The following is a description of a gene set: Mouse Gene Set: ANP32E_TARGET_GENES from publication Yevshin I, Sharipov R, Kolmykov S, Kondrakhin Y, Kolpakov F (PMID 30445619) studied in species Mus musculus Genes containing one or more binding sites for (Anp32e) in their promoter regions (TSS -1000,+100 bp) as identified by GTRD version 20.06 ChIP-seq harmonization., and this is the list of marker genes: Rdh5, Rbms1, Eef1a1, Mir1955 (microRNA 1955), Fnbp4, Casp8ap2, Gm15991, Bloc1s1, Zfr, Fbxo46, Gcc1, Lrif1, Hexim2, Dctn4, Ten1, Kctd12, Spata2, Gm22711, Cradd, Slc38a2, Polr2m, Rnase4, Abcb10, Pim1, Osbp, Wbp1l, Parp11, Gm37885, Spaar, Snapc3, Incenp, Tmem150a, Snrpg, 2610005L07Rik, Ddah2, AA914427, Ubl3, Mtbp, Dnttip1, Prim1, Mettl2, Hivep1, Ciao1, Hadhb, Fry, Rab14, Mrpl24, Atpsckmt, A230083N12Rik, Eml4, Mir207, Flna, Zranb2, Atox1, Sgk1, Sh3yl1, Hmg20b, Ubap1, Wdr83, Cnot3, Yap1, Nt5c3, Tpp2, Fam222a, Cenpi, Zfp335os, Frmd8os, Gm23130, 2310057M21Rik, Zfp282, 1110038B12Rik, Gbp6, Tmem18, Tcof1 (treacle ribosome biogenesis factor 1), Med24, Slc35f5, Mul1, Gm26590 (predicted gene, 26590), Elk4, Zfyve19, Nck1, Sde2, Nfat5, Cdk2ap2, Zfp395, Prorp, Acyp1, Fastkd1, Fermt2, Bscl2, Ttc7, Tesk2, Hif1an, Rnu11, Zmynd8, D830032E09Rik, Hmg20a, Gm15927, Usp21, Gapdh, D6Wsu163e, Gm25296, Utp3, Cdkal1, Por, Evi5l, Tsen34, Steap1, Cmah, Dpf3, Abhd18 (abhydrolase domain containing 18), Kdm1b, Fgd4, Ppme1, Mir7009, Abcd3, Hibch, Hbp1, Tcp11l2, Taf1, Tmem126b, Fryl, Mtmr14, Capzb, Clptm1, Trim23, Septin11, Mindy2, Slc15a4, Cstdc2 (NCBI Gene Id 77705), Tmed8, Tsg101, Srsf5, Lamtor3, Cchcr1, Gsk3a, Anapc10, Tmem59, Commd5, Wars2 (NCBI Gene Id 99607), Sra1, Zfp384, Nans, D8Ertd738e, Prkra (NCBI Gene Id 99272), Snf8, 1600020E01Rik, Them4, Tpmt, Opn3, Rnh1, Wbp2, Spg11, Nosip, Spaca6, Gm15535, Fam76b, Vps13d, Sub1, Ppih, Nap1l4, Tmem38a, Setd1a, Nfkbib, Rps12, Fis1, Ice2, Zfp949, Traf7, Abcd4, Tspyl2, Nop58, Meis1, Lifr, Tcf4, Evl, Park7, Ap2b1, Sart3, Zfp940, Mir8111, Ppp1r7, Cactin, Bcl2l11, Rps29, Zc3h8, A430018G15Rik, Ing4, Rrp15, Snrpb, Tmcc2, Med20, Trappc6a, Anapc13, Ube2v1, Irgq, Tpd52l2, Fancc, Hspa9, Yy1, Coa7, Tmem127, 4933434E20Rik, Cyp27a1, Rny1, Dph2, Nuf2, Serinc5, Acox1, Xrcc5, Prpf40a, Ints6, Bad, Yars1, Cyld (CYLD lysine 63 deubiquitinase), Aplf, Stim2, Exosc4, Cyp39a1, Cenpa, Leprot, Rrp9, Nampt, Fiz1, Zbtb17, Srsf1 (NCBI Gene Id 70724), Lsg1, Chchd7, Dcun1d4, Rpsa, Clec14a, Itpripl1, Crem, Mtrf1l, Smg7, Mrpl47, Dock9, Gm5914, Mindy1, Nr6a1, A130014A01Rik, Gpr137, Clec2d, Hexim1, Txnl1, Mir8098, Thtpa, Azin1, Wdr37, Zfp524 (zinc finger protein 524), Gm20517, Rplp2 (NCBI Gene Id 67186), Wdr12, Dexi, Hadha, Arhgap39 (NCBI Gene Id 28124), Tnpo2, Atp5me, Irak1, Cask, Slc19a2, Cct5, Garnl3, Lztfl1, Tpt1, Gmfg, Itpr1, Phf6, Nfatc2ip, Ufl1, Clpp, Snrnp35, Arhgap19, 4930432B10Rik, Rcan2, Rit1, Med1, Seh1l (NCBI Gene Id 72124), Grk4, Kif9, A530072M11Rik, Usf1, Dsel, Pdpk1, Zfp46, Camk2d, Acaa1a, N4bp2l2, Rad51ap1, Sp2 (Sp2 transcription factor), Abcb8, Rufy1, Ufc1, Ice1, Mir8105, Arih1, Amd1, Gtf2a1, Emg1, Pacsin2, Hdgfl2, Cul4b, Exo5, Crim1, Lgals1, 1700008O03Rik, Arl6ip1, Tomm34, Lta4h, Pja1, Calm1, Rasl11b, Snhg16, Pbld2, Rimoc1, Xpa, Ube2c, Rab43, 1700030K09Rik, Arhgap21, Setd3, 1700045H11Rik, Tspan12, Acp6, Myl6b, Mon1a, Sap30, Camta2, Oga, Sacm1l, Dip2c, Etv5, Rab3a, Hdac2, 4833418N02Rik (NCBI Gene Id 74597), Tatdn2, 4930429F24Rik, Tssk6, Atxn2l, Mrpl13, Arl6ip6, Fbxo36, Gcat, H2ac5-ps, Apeh, Dnai2, Tstd2, Mrps9, Fpgs, H3c7, Mcrip1, Bnip2, Ndufb11, Sh3bp4, Edrf1 (NCBI Gene Id 72581), Odad1, Ociad1, Mir133a-2, Cdiptos, Ccdc85b, Agrp, Zfp335 (zinc finger protein 335), Ddx3x, Eif1a, Idh1, 5930403N24Rik, Kpna2, Fbxo30, Zxdc, Dcaf11, D230022J07Rik, A430105J06Rik, Zfp60, BC005537, Mtmr4, Igfbp4, Cdca7, Exosc10, Lsm14a, Ift70b, B9d1os (B9 protein domain 1, opposite strand), Arhgef1, Cep57, Zfp322a, Ing3, Lsm14b, Spen, Stx4a, Rasd1, Sfr1, Vgll4, Bcas3, Gm15938, Srrm1, Hrob, Slc9a8, Ccdc97, Hspb1, Atp6v1c1, Errfi1, Mir1960, Arhgap4, Zfp939, Fndc11, Slc35b1, Abca4, Gm11423, Kif16b, Stoml2, Gstz1, Top1, H3c13, Sufu, Wdr83os, Eeig1, Adsl, Ehd2, Slc25a32, Tsc22d3, Rpl29, Arhgap27, Tbc1d9b, Trmt12 (tRNA methyltransferase 12), Stn1, 5031434O11Rik, Ap5s1, Atp5mc3, Akirin1, Igfbp5, Lipe, Dad1, Gm31266, Ppp2r5b, Selenoh, Rpl22l1, Msh3, Guk1, Irf3 (NCBI Gene Id 54131), Lrrc56, Akirin2, Crebrf (CREB3 regulatory factor), Zfp653, Rnf7, Jade1, Rab26os, Orc5 (origin recognition complex, subunit 5), Fam117b, Gm24576, Llgl1, Gm5106, 4930505A04Rik (RIKEN cDNA 4930505A04 gene), 5730420D15Rik, Mrps17, Smarcc1, Tsr1, Unc13a (unc-13 homolog A), Snord60, Dyrk1a, Zfp106, Klhl18, Supt20, Mcm5, Pafah2, Armt1, Dusp3, Sp3, Rmnd1 (NCBI Gene Id 66084), Gnas, Fbl, Usp2, Selenok, Map4, Mrpl10, Nsun3, Tap2, Smim30, Ruvbl2, Kptn, Mynn, Dpm2, Pias1, Actr1a, Zcchc14, Yod1, Gm5493, Gmeb1, Sdhaf4, Rps14, Iqcg, Cdc37, Pelo, Pym1, Esco2, Dcaf13, Trp53bp2 (transformation related protein 53 binding protein 2), Rack1, Phb2, Rpa2, Fxr2, Ints9, Yme1l1, Sf3b4, Ttc8, Rbpms2, Eif3b, Carf, Tars2, Get4, Psmd3, Ripk2, Srd5a3, Slx4ip, H2bc3, Tor2a, Il6, Usp32 (NCBI Gene Id 77025), Trip12, Etfb, 4930581F22Rik, Tmem268, Il1rap, Snord118, Socs2, A130010J15Rik, Ppp6r1, Atp5mc1, Deptor, Bcor, Inppl1, Fmnl3, Rnf181, Stxbp3, Smarcc2, Mtmr11, Zfp62, Upf2, Hnrnpll, Tmem183a, Pigm, Kdm6a, Las1l, Rnf122, Nphp1, Eps15l1, Dgat1, Ech1, Tnrc6a, Sgsm2, Dus3l, Frs2 (NCBI Gene Id 327826), Dph6, Ssmem1, Zfp787, B9d1, Anapc15, Rint1, Hras (NCBI Gene Id 15461), Asap1, Cep126, Cavin2, Srpk2, Cdipt, Mir22hg, Zkscan5, E230015B07Rik, 1110019D14Rik, Hes1, Slc25a23, Rae1, Eml6, Nectin3, Med15, Ddx24, Otub1, Cct6a, Rps26, Gm13421, Prr14, Gm11457, Gm23639, Lrpprc, Emc9, Tubgcp5, Ankib1, Poc5, Tmem128, Elf2, Ttc33, Tnrc6b, Prkci, Slc35a4, Coro1c, Chfr, Tmed1, Dnaja1, Nr3c1, Dnajb5, Gatb, Cyb5a, Arrdc3, Psph (phosphoserine phosphatase), Polr2c, Rbbp5, Phf14, Yars2, Cnot9, 4933439C10Rik, Snora7a, Hnrnph1, Obi1, 4930412C18Rik, BB557941, Gm4189, Ubap2l, Slc12a6, Arhgap29, Hspb2 (NCBI Gene Id 69253), Stamos, Commd6, Pcbp1, Tcerg1, Adprs, Epb41l4aos, Hjurp, Gm30270, Slc25a11 (solute carrier family 25 (mitochondrial carrier oxoglutarate carrier), member 11), Gm26524, Gys1, Srsf10, Parl, Flywch1, Klhl21, Sap30bp (SAP30 binding protein), Lars2, Prrg2, Abhd16a, Nr4a1, Taf11, Gm15545, Epn1, Traf6, Lrrc46, Timmdc1, Prr12, Agl, Abhd5, Srprb (NCBI Gene Id 20818), Nop53, Med11, Wdfy2, D430040D24Rik, Schip1, Crebl2 (cAMP responsive element binding protein-like 2), Egr2, Gna12, Dbp, Cbx5, Zswim4, Brd3, Rbks, Cfap418, Shc1, Ufm1, Atxn1, Tceanc2, Nfatc2, Dpagt1, Zmynd12, Rnf167, Lgmn, 1810062G17Rik, Capns1, Htt, Plekhg2, Ift56, Mef2c, Bsdc1, Pdk1, Dhodh, Arpc5, Ppcs (NCBI Gene Id 67987), Gm16170, Gm16133, Agrn, Pex12 (NCBI Gene Id 103737), Pkd2, Rpa1, Gm6712, B230369F24Rik, Aars1, Trib1, Arid4b, Ccnk, Wdr43, Slc7a1, Iqgap3, Ppp1r15a (NCBI Gene Id 63956), Ggps1, Gimap4, Copb2, Cd274, Plekha4, Cyc1, Dicer1, Phkg2 (phosphorylase kinase, gamma 2 (testis)), Gm10039, Krit1, Atxn7l3b, Tgs1, Slc16a13, Rc3h2, Rhof, Pip5k1c, Jkamp, Hey2, Farsb, Dhrs7, Mycbp2, Dtl, Ptgfrn (prostaglandin F2 receptor negative regulator), Zfp708 (zinc finger protein 708), Tuba4a, Gm10575, Lman1, Hsd17b10, Rfx3, Rab35, Gm4285, Otud5, Tmem9, Rapgef6, Dcun1d3, Rhoq, Rfwd3, Pigu, Med31, Hnrnph3, Mir5130, Pcyt1a, 4930558K02Rik, Zng1, Pikfyve, Lockd, Ndufc1, Tjp2, Tmem123, Sys1, Rrm1, Wrap53, Arl5a, Zfp91, Patl1, Capn7, Ndufa4, Ccdc85c, Dync2i2, Cox20, Btbd3, Ppp1cc, Irf8, Zdhhc7 (zinc finger, DHHC domain containing 7), Slc39a10, Mastl, Med16, Gpr155, Zfp12, Btbd1, Trpm8, Sgo2a, Samd15, Tmem87b, Rel, Zfand3, Zfp235, Col23a1, Lbh, Morf4l1, Coil, Aifm1 (apoptosis-inducing factor, mitochondrion-associated 1), E230029C05Rik, Popdc2, 4921504E06Rik, Rps8, Amigo2, Trim69, Sh3glb1, Mtx1, Nolc1, Arhgef18, Egln2, Ap1g1, Clasp1, Mto1, Usp19 (NCBI Gene Id 71472), Large1, Pithd1 (PITH (C-terminal proteasome-interacting domain of thioredoxin-like) domain containing 1), Gm32950, Pfkfb2, Tlcd2, Nme7, Ackr3, Itfg2, Lyrm1, Zscan26, Tmbim6, Haus1, Gns, Ergic2, Supt16, Hmbox1, Mir718, Vps25, C230035I16Rik, Rhoc, Iscu, Limk1, Vrk3, Lnpep, Tmem68 (NCBI Gene Id 99971), Ubxn1, Mir5132, Ift46, Smim7, Mir6975 (NCBI Gene Id 102465589), Psmg1, Vars2, Dazap1, Usp37, Trip4, Cipc, Pcf11, Cars2, Gm25541, Gm17690, Ptprs, Khk, Usp3, Rock1, 4930481A15Rik, Ttn, St3gal4, Prkrip1, Edem3, Adipor2 (NCBI Gene Id 68465), Bcl2l12, Tpt1-ps1 (NCBI Gene Id 676538), Csnk1g1, Ddx19a, Bola1, Mrps7, Bloc1s3, Ubtf, Lrrc28, Gm11175, Mvb12a, 4930521E06Rik, Trp53rka, Hibadh, Tmem209, Ptar1, Gtpbp2, Tmem167b, Hlx, Ccng2, Dhcr7, Get3, Dnase2a, Pmepa1, Ppp1r3a, Mir7228, Ndufb5, Rpl22, Rab28, Ndufb2, Slc25a27, Adgre5, Numb, Eapp, Zkscan1, Gm15441, Phf19, Nfe2l1, Junos, Hspb6, Tgds, Snord104, 6030442K20Rik, Ppargc1a, Slc25a25, Snai2, Zcchc7, Neat1, C920021L13Rik, Depdc1b, Ddit3, Asah1, Nfx1, Mkks, Pdk4, Prkag2, Pakap, Stam, Wdhd1 (NCBI Gene Id 218973), Erbin, Acp1, 4930578M01Rik, H2ac19, Bhlhe40, 1700120C14Rik, Dusp1, Catspere2, Marcks, BC004004, Cln3, Tmem138, Uvssa, Sertad1, Tnks1bp1, Med6, Ifrd2, Gtpbp1, Polr1f, H4c9, Ftl1, Ppip5k2, Tmem69, Mtx2, Lrrc8d, Rsbn1l, Gm5590, Mrpl1 (mitochondrial ribosomal protein L1), Peak1, Rbm27, Nt5e, Gtpbp3, Prn, Ythdf2, Tcf19, L3hypdh, Snord12, A230028O05Rik, Bcl2l2, Rpl32, Tmem106c, Mfsd8, Ddx27, Rpl35a, Dars2, Slc25a15, Tmem39b, Xbp1, Trappc13, Faap20, Cdc42ep4, Rnpepl1 (arginyl aminopeptidase (aminopeptidase B)-like 1), Srrm2, Stk11ip, Tmub2 (transmembrane and ubiquitin-like domain containing 2), Kat2a, Agtpbp1 (NCBI Gene Id 76578), Gm25744, Hdac1, Nelfa, Dcaf1, Tmpo (thymopoietin), Yipf4, Zfp94, Tfe3, Abhd4, Gm11292, Wwc2, Psmc4 (NCBI Gene Id 23996), H2ac21, Nr1h2, Gm16675, Ercc2, Uqcc3, Pi4kb, Ssbp3, Kdm4c, Clta, 4930592C13Rik (RIKEN cDNA 4930592C13 gene), Prdm4, Myc, Tmco6, Zfp462, Fh1, Ophn1, Pogz, Cuta, Ddo (D-aspartate oxidase), Timm21, Nme1, Zcwpw2, Naa10, Phb1, Cln6, Kdm5a, Sik1, Ssrp1, Gm26330, Midn, Hcfc1, Bmf, Cenpn, Cks1b, Zfp473, Wipf1, Chmp7, Dctn1, Tsc22d1, Mboat7, Tmed7, Baz1b, Tmem30a, Snupn, Tmem19, Timm8b, Asxl1, Traf3, Ap2s1, Cenpl, Opa3, Blzf1, Atp6v1f, Alkbh5 (alkB homolog 5, RNA demethylase), Pou2af3, Aptx, Mark2, Pdcd4, Xiap, Zfp41, Prnp, S1pr2 (sphingosine-1-phosphate receptor 2), Zbtb7b, Shb, Lasp1, Naa35, Cep63, Rpl36a, Cpd, Brd7, Recql5, Ttc19 (tetratricopeptide repeat domain 19), Slc25a35, G6pc3, Pex5, H2az2, Syncrip, Ado, Brd10, Snord55, Plgrkt (plasminogen receptor, C-terminal lysine transmembrane protein), H4c4, Rbm10, Rpl10, Atp6v0a1, 1700113A16Rik, Ipp, Atf1, Cd2ap, 1110002J07Rik (RIKEN cDNA 1110002J07 gene), Slc39a1, Ndufs4, Cmc2, Ptpa (NCBI Gene Id 97035), Ccar1, Tspan31, Pask, Ncbp1, Zfp263, 1700030J22Rik, Nr4a3, Bicdl1, Srcap, Arpc3, Nfatc3, Rnf19a, Gm23201, Jade2, Ostc, Atf7ip, Mrps21 (NCBI Gene Id 66292), Top2a, S100pbp, Map4k5, Exoc7, Ang, Nrde2, Slc25a5, Khsrp, Tsc1, Tex2, Nfkb2, Csrp1, Donson, Nudt13, Pkia, Sirt2, Epas1, Rhog